The following is a description of a gene set: studied in species Homo sapiens from publication Yevshin I, Sharipov R, Kolmykov S, Kondrakhin Y, Kolpakov F (PMID 30445619) Human Gene Set: SOX10_TARGET_GENES Genes containing one or more binding sites for (SOX10) in their promoter regions (TSS -1000,+100 bp) as identified by GTRD version 20.06 ChIP-seq harmonization., and this is the list of marker genes: CD96, NFIA-AS2, MIR802, AKAP7, SMC6, C5orf22, EGLN3, AMOTL2, PPP2R2B, ANK3 (NCBI Gene Id 288), CYP27A1, ERBB3, ADAM12, MIR4780, R3HDML-AS1, MGAM2, ZFYVE19, TRAPPC12, CD300LD-AS1, LIMCH1, COPB2, MARK2, LINC01802, ST3GAL4, ZNF664, TGFBRAP1, CDH19, SLCO4A1, CAPN3, AKAP12, UBA6-DT, MUC20-OT1, PLEKHA7, LHFPL3-AS1, DAB2, EEIG1, TRPC6P5, ZNF24, KIF25, MMP8, AP3M2, GJB1, RECQL5, GAS2L3, RPS4XP14, FARP2, USP17L24, RAB7B, NTN4, LINC01301 (long intergenic non-protein coding RNA 1301), RFX4, FADS2, GAS7, SEPTIN8 (NCBI Gene Id 23176), CEP97, CDIP1, LINC03057, PI16, SOX6, RGS20 (NCBI Gene Id 8601), LINC00992, KDM3A, DLGAP1-AS2, NFYCP2, CFLAR-AS1, PLEKHB1, DTHD1, HOXA-AS2, DHX29, NWD1, MIR3142HG, COL9A1, ECHDC1, DLGAP1-AS1, CDK2AP1, MIR3116-1 (NCBI Gene Id 100422902), ST3GAL6, IFT80, RHOJ, FOXP1, TMED10, RN7SL50P, LINC01531, ARPC1A, USP54, NELFCD, SPEF2, GMFBP1, MAPRE2, PHACTR4, LINC01588, ATOH8, RNU4-18P (NCBI Gene Id 106480545), MBNL1, BCL2L13, SLC22A23, LINC02895, SASH1 (NCBI Gene Id 387570), LINC01549, USP28, LINC02765, HDAC4, ANKRD28, SPATS2 (spermatogenesis associated serine rich 2), SOX5, MCC, SLC16A4, LINC01060, MRTFA, TMX4, QPCT, CCSER2, KIFC3, TMEM139, TTLL4, FUBP1, NDE1, NUP214 (nucleoporin 214, NCBI Gene Id 9680), PLEKHH1, FOXO3 (forkhead box O3), OR4A9P, LINC01554, CP, GAPDHP72, SORBS2-AS1, PDE4B, RMEL3, C3orf49, NUDT6, RNU6-1, H1-9P, ZC3H7A, DLC1, USP32, MED15, LINC00052, CLIP4, CHI3L2, RNVU1-34, ADAMTSL3, TMEM67, SMC4, CERK, EIF3E, OR10B1P, DGKI, RPL41, PDXP, OTUD3, MTMR12, TLR6, GRAP2 (GRB2 related adaptor protein 2), ZFP30, DCT, FEN1, PSMA5, OR8R1P, ACSS1, INTS13, TRIM51, EXOSC4, LINC02613, RPL35AP26, CSRP2, HCCAT5, LINC01034, FGD4, RPL12P19, DIO2, MIA, RUBCNL, TRPS1, TRAF3IP2, PI4KB, CCDC13-AS1, SEPTIN9, ZHX3, SNORA80A, GPRC5D-AS1, SLAIN1, BIN3, LINC01291, ZNF608, SCML4, TMEM246-AS1, NFIA, OC90, TPM4, ATM, CRPP1, SLC38A9, LINC00518, TMPRSS7, ZNF197, RPL12P11, OR7A5, NMRAL2P, GEMIN8, CLDN22, VMP1, PRKCH, MMACHC, MITF, ISG20, RDH11, GIPC1, TBXAS1, ACADSB, MTUS1, LRRFIP2, PGK1, LINC02938, ZNF781, MUTYH, PBRM1, RNF145, KIF23, ATP6V0A4, LINC00862, PLCH1, PACRG-AS3, H3C6, LINC01619, LINC00427, STX6, INPP4B, DGLUCY, BCAN-AS2, LINC00466, KANK1, LRP2BP, SLC38A2, IGF1R, CTTNBP2, PLPPR1, LAMB3, LINC02121, RPL15P19, RHOBTB3, SMCR2, SLC12A8, FABP5P7, C2orf88, SNRPFP3, SELENOT, UBE2Z, MAD1L1, NEK9, LINC00639, GPR107, NT5DC3, PTPN11P3 (PTPN11 pseudogene 3), DROSHA, FAM167A-AS1, PACSIN2, LINC03122, FBXO7, PRICKLE1P1, ADD1, CDK2, RPL36P5, ENSG00000233539, SDHC, SLCO4A1-AS1, WRN, HP1BP3, RNF144A, BBS5, OPHN1, CDC42EP1, ENSG00000266088, PTPRK-AS1, LAMA4, COMT, TRAK1, PLCH1-AS1, TNKS, RPS27P22, CLDN20, CFAP61, ALDH9A1, MIR759, SORL1, CTNNA1, LINC03048, RNY3P11, GORAB-AS1, FAM118A, LINC03109, SPATA20, SPTBN1, IFT81, LSAMP, NLRC5, DLEU1, NRP2, MFSD11, ARL8BP2, SH3KBP1, PCBP1-AS1, MIR570, CNEP1R1, MYL10, ANO2, SMYD1, OARD1, TMPRSS5, RPSAP65, AADACP1, KCNAB1, DOCK7 (dedicator of cytokinesis 7), RNF216, NEDD9, LNCRNA-IUR, LINC03002